The following is a description of a gene set: Human Gene Set: HE_LIM_SUN_FETAL_LUNG_C4_CYCLING_NK_CELL from publication He P, Lim K, Sun D, Pett JP, Jeng Q, Polanski K, Dong Z, Bolt L, Richardson L, Mamanova L, Dabrowska M, Wilbrey-Clark A, Madissoon E, Tuong ZK, Dann E, Suo C, Goh I, Yoshida M, Nikolić MZ, Janes SM, He X, Barker RA, Teichmann SA, Marioni JC, Meyer KB, Rawlins EL (PMID 36493756) studied in species Homo sapiens Cycling NK, and this is the list of marker genes: NAA50, TPRKB, SPAG5, RFC5, PRPS1, USP39, SLC25A1, WDR76, PSMC3IP, PDLIM1, APOBEC3B, DAB2, KIR3DL1 (NCBI Gene Id 439925), RRM2, CENPK, PHTF1, SPATA33, USP48, CEP43, UBXN2A, RHNO1, CBFB, ACYP1, DNAJC9, UHRF1, POP7, KIF20A, H3C7, CRTAP, VANGL1, CENPQ, KIF18B, RMI2, CDKN1A, RAD51C, NSL1, PXMP2, SH3GLB2, METTL4, H4C11, MCM10, PAQR4, G2E3, SAMD1, CDK2, TOR2A, MPC1, CENPW (NCBI Gene Id 503503), SMCO4, HSPA13, DTL, DONSON (DNA replication fork stabilization factor DONSON), MCMBP, SLC43A3, ACAT2, BIRC5, H2AC16, CPSF3, H2AC14, HPF1, ACOT7, RECQL4, H2AC15, LMNB2, GMPPB, TIMM21, COMMD4, PIGX, NCAPH2, SCMH1, BAG2, SLC1A4, DSN1, CLN6, SCCPDH, H2BC7, HJURP, ZNF672, KIF23, STIL, MCUR1, PCNT, MXD3, CPXM1, MPST, KNSTRN, TCF19, H2AC17, HELLS, NCAPH, POGLUT3 (NCBI Gene Id 143888), FANCG, UBE2S, BARD1, TROAP, MMAB, ILVBL, GPN3, POLH, H3C2, MCM4, INCENP, FAR1, ACAD9, CCNE1, FABP5, GMNN, RHEBL1, H2BC9, CENPA, CENPE, SP2, CDC6, DLEU2, LIN9, STRADA, CDK19, FAM83D, RNF26, VRK1, DEPDC1B, BRCA1, ASRGL1, FOXRED1, HAUS2, H2AC21, PRPS2, CIDEB, CDCA7, BUB1, ATAD3A, KIFC1, RCC1, TMPO-AS1, SYNE2, PTTG1, CDCA5, ITGB3BP, NCAPG, PGP, FANCL, AKIP1, HMGB3, TRIP13 (thyroid hormone receptor interactor 13), MTRFR, KIF11, ZGRF1, CCNE2, SLC2A4RG, TIMM10, RMI1, CEP55, CENPL, HADH (NCBI Gene Id 3033), ZWILCH, TSPAN4, CEP78, NEIL3, CDK1, WDHD1, LIG1, RACGAP1, TRIM28, DCAF15, GINS3, IFI27L1, SFMBT1, SMPD4, FHOD1, GSS, H4C14, SHMT1, TLNRD1, FANCD2, CENPH, ZWINT, KIF14, MAD2L2, PRC1, TPX2, RAD51AP1, MASTL, PSMG3, ANKRD36, NDC80 (NCBI Gene Id 10403), UBR7, NEMP1, ASB16-AS1, TYMS, TFDP1, GNGT2 (NCBI Gene Id 2793), SEPHS1, HMGXB4, SLF1, H3C8, ARL6IP6, CKAP5, E2F3, MFSD14B, H4C4, WDR5, C1orf35, H2BC15, KMT5A, PHF19, THOP1, SMC6, MDM1, CENPF, USP1, DTYMK, CCDC34, ASF1B, DARS2, WWOX, MKI67, TTF2, RBL1, CCDC18, ZW10, TRIM24, UBE2T, KIF20B, H3C14, TOPBP1, ATP2A2, CEP192, ARHGAP11A, CCNA2, JPT2, SESTD1, CBX5, EXOSC3, E2F7, TACC3, FEN1, MYBL2, PRPSAP1, BLVRB (NCBI Gene Id 645), SAC3D1, HMGCS1, MTHFD2, UBALD2, MUTYH, RFC4, SGO1, SPDL1, ZNF574, H2AC4, SLFN13, GINS1, CEP295, MICB, MAGOHB, PCNA, POU2F1, OIP5, CDCA4 (NCBI Gene Id 55038), NCAPG2, PRDX4, CCNB1, CKAP2L, MGME1, POLD1, E2F2, UBE2C, RELT, NUSAP1, CXXC1, SVIP (NCBI Gene Id 258010), RDX (NCBI Gene Id 5962), ANKRD36C, BRI3BP, SHCBP1, MTG2, ZNF346, PSRC1, NCAPD2, MMUT, RFC3, PPCDC, CCDC14, NDC1, BTG3, CDC23, GTSE1, H2AC13, MCM5, MSH6, EXO1, WEE1, TRNAU1AP (tRNA selenocysteine 1 associated protein 1), CASP8AP2, APEX2, TM7SF3, TMEM209, MLH1, GON7, GLO1, CDKN3, NFYB, CPSF4, DEPDC1, PSMD14, H3C15, ACD, H2BC3, ATG16L2 (autophagy related 16 like 2), USP14, SMC2, ARHGAP33, H3C3, DBF4, SLC27A3, ESCO2, RANGAP1, C17orf58, SLC25A40, NRM, PPIF, RAD51D, TUBGCP3, ECT2 (epithelial cell transforming 2), THEM6, H3C10, H2AC12, FAM111B, GINS2, CDKN2C, CCNF, ARHGEF39, TMEM106C, ATAD5, LRRC40, ORC1, LMNB1, JMJD4, FBXO5, PTBP2, LMF2, HAUS8, FANCI, H1-5, POP4, MCM3, RCCD1, SAR1A, MND1, UBE2M, FN3KRP, H4C15, E2F1, CENPP, SUV39H1, H4C6, TOR3A, CCP110, FBXO4, CDK5RAP2, DIAPH3, SNTB2, MIS18BP1, SLC25A25, KIF15, MCM2, CDC20, PSMG1, CEP85, DNA2, TUBG1, CDC45, FAF1, KIF2C, REXO5, H2BC11, CLSPN (claspin), PRIM2, LIN54, NUP107, BUD13, KLRK1, CETN3, OXCT1 (NCBI Gene Id 7898), H4C12, KNL1, MTHFD1, CENPO, NABP2, E2F8, SLC29A1, MGST3, SKP2, USP37, BCAP29, CDCA7L, ORC6, TRAF2, TMEM97, MFGE8 (milk fat globule EGF and factor V/VIII domain containing), PDZD11, LRR1, ALYREF, GSTM1, EXOSC8, CHTF18, RANBP9, GMPS, DDX11, CDC7, EME1, SIMC1, MIR4435-2HG (NCBI Gene Id 541471), SUZ12, SLC43A1, PTPN18, NUDT1, GPANK1, CMC2, TIMELESS, CFAP20, RFC2, H2BC18, REEP4, PIDD1, CDC27, ABHD3, KNTC1, CKAP2, TEX30, POLE2, KIR2DL1 (killer cell immunoglobulin like receptor, two Ig domains and long cytoplasmic tail 1), TIFA, TOE1, GINS4, RBBP8, MRPL55, RCC2, H1-1, TPGS2 (tubulin polyglutamylase complex subunit 2), ZDHHC12, AP1S1, ANLN, NIT1, MZT1, CENPN, DLGAP5, BAZ1B, CKS1B, ASPM, EMC9, DSCC1, MLC1, MCM7, RIF1, AKT1, HMMR, BRCA2, MELK, ZDHHC4, ARL6IP1, CTNNAL1, NNT-AS1 (NCBI Gene Id 100653173), C21orf58, ATP23, DPM2, KIF22, RFWD3, CCDC28B, HLTF, WDR54, PMVK, PKMYT1, CENPJ, PPM1D, THAP7, NUP85, RBM14, STX11, TMEM107, CHAF1A, DDB2, NUP50, OTULINL, FOXM1, NUP37, XRCC1, H2AC11, POC1A, CTCF, PDS5B, SASS6, BUB1B, FANCA, PBK, NQO2, FUZ, SLC25A16, TEDC1, CCNB2, CENPU, TBL3, BCL2L12, MAP3K20, PARP2, CEBPG, EBP, ABHD11, PRIM1, LIN52, FAM76B, FBXL6, CTBP2, SPATS2, SFR1, NTAN1, RPL39L, FAM111A, CCDC82, BLVRA, H2AC8, POLA2, HTRA2, ENOSF1, FAM111A-DT (FAM111A divergent transcript), H4C1, RUSC1, AURKB, DYNC2I2, RNF168, H2BC13, CEP57L1, KAT5, EXOSC9, TDP1, TNPO3, POLE, UCK2, RRM1, SNRNP25, CEP152, LRRC59, KIF4A, SKA1, ABHD10, ZNF738, CNTLN, TOP2A, SAAL1, NCAPD3, HDGF, MIS18A, EED, PHGDH, NUF2, CYTOR, MSH2, DERA, FMR1, NUDT15, RAD1, GNL1, POLD3, PCLAF, CDCA2, CIP2A, CDCA8, MPHOSPH9, KLRC2 (NCBI Gene Id 3822), MAD2L1, H4C8, CHST2, SKA3, HAT1, POLQ, HAUS6, PPP5C, CENPM, WDR62, ATP1B3, XPO1, TCHP, H4C13, UBXN11, GUCD1 (guanylyl cyclase domain containing 1), HCFC1R1, RAD9A, LRRC45, NFATC2IP, TTK, PUSL1, MIS12, UEVLD (UEV and lactate/malate dehyrogenase domains), PDLIM7, THOC1, BLM (NCBI Gene Id 641), SEPTIN11, CTNNBIP1, IL12RB2, TP53I13, KIF18A, GGH, TRAIP, ORC3, SPC25, SQLE, CHAF1B, PANK2, MCM6, NSD2, KEAP1, BORA, MED7, DHFR, SYK, H3C12, CHEK2, GALE, SLC1A5, PRADC1, C4orf46, CHAMP1, HAUS5 (HAUS augmin like complex subunit 5), CTPS1, AHI1, TCEAL3, SKA2, RAB27A, RAD54L, H2BC4, UBL7-DT, TAF1B, SPTSSA, ARMC1, PRIMPOL, HIRIP3, CHEK1, SPC24, TMEM18, CHRAC1, CCDC88A, GUSB, WRAP53, CTDSPL2, HDGFL3, RUVBL2, C19orf48P, HAUS1, TEDC2, RBM15, PARP16, LRRCC1, RNASEH2A (ribonuclease H2 subunit A), JADE1, EZH2 (enhancer of zeste 2 polycomb repressive complex 2 subunit), SMIM13, LGALS1, YEATS4, CX3CR1, CDT1, MTFR2, CDK16, ST3GAL4, TCF3, GATAD2A, LRRC42, PLK1, EXOSC10, RAD54B, UBL4A, MCM8, CDCA3, ZNF367, PMM1, SRGAP2B, CGAS, H2AC20, HAUS4 (NCBI Gene Id 54930), FIRRM, RAD18, POLA1, ICMT, CNTROB, KPNA2, CTBP1, ACTL6A, SGO2, ATAD2, TIPIN, PIMREG, VPS26A (NCBI Gene Id 96725), CCNJL, ZNF85, AURKA, TK1 (NCBI Gene Id 7083)